Given this list of marker genes CCR1, FOXE3, SCNN1G, CEACAM6, SERPINA1 (NCBI Gene Id 5265), HFE, MAT2A, SLC34A2, MLX, IL17RA, GIMAP5, SLC26A9, SMAD4 (SMAD family member 4), FAS, HMOX1, TGFB1, STX1A, EIF2AK4, IL17F, CLEC7A, ELN, TGFB2 (transforming growth factor beta 2), KCNN4, HLA-B (major histocompatibility complex, class I, B), IL10, C4A, IL17RC, F5, COL3A1, ERAP1, TSC2, ENG, HLA-DPB1 (NCBI Gene Id 3115), SLC6A14, STAT4, IFNG, ODAD1, IFNGR1, SLC9A3, DCTN4, TGFBR1, UBAC2, SLC11A1, HEY2, IL23R, FBN1, SMAD3, MEFV, GDF2, GSTM3, CEACAM3, PRKG1, TGFB3, HLA-DPA1, COL5A1, COL5A2, CTLA4, SCNN1A, IL12A-AS1 (NCBI Gene Id 101928376), FCGR2A (NCBI Gene Id 90764), SCNN1B, CLCA4, MYLK, THSD4, ARPC5, CFTR, TLR4, MFAP5, LOX, DNASE1L3, HLA-DRB1, PTPN22, KLRC4, IL12A, IL12B, GCLC, ACVRL1, ACTA2, PRTN3, MIF, TRAF3IP2, MYH11, TLL1 (NCBI Gene Id 7092), TGFBR2 (NCBI Gene Id 7048), SMAD2, EDNRA, BTNL2, TSC1, here is a description of the gene set: Hemoptysis species: Homo sapiens Coughing up (expectoration) of blood or blood-streaked sputum from the larynx, trachea, bronchi, or lungs. Human Gene Set: HP_HEMOPTYSIS